Given this list of marker genes Upf1, Cnot6, Hnrnpab, Upf2, Igf2bp1, Ctif, Ssb, Smg7, Parn, Tut1, Tob1, Mtpap, Ptbp1, Pabpn1l, Gtpbp2, Xrn1, Samd4, Pan3, Eif3e, Pym1, Cnot8, Patl2, Zc3h12a (NCBI Gene Id 230738), Pde12, Dcp1b, Apobec1, Thrap3, Magoh, Rbm8a, Smg8, Smg1, Smg9, Pelo, Smg5, Cnot6l, Dhx34, Pnrc1, Edc3, Atm, A1cf, Tut4, Samd4b, Smg6, Cnot3 (CCR4-NOT transcription complex, subunit 3), Eif4a3, Rc3h1, Ddx5, Secisbp2, Exosc5 (exosome component 5), Paip1, Exosc9, Patl1, Syncrip, Polr2g, Lsm1, Hnrnpd, Dxo, Tent4b, Exosc2, Ago2, Etf1, Gspt1, Dcps, Rc3h2 (NCBI Gene Id 77277), Lsm4, Lsm7, Tnrc6c, Eif4enif1, Casc3, Caprin1, Upf3b, Cnot7, Dis3l2, Ncbp2, Eri1, Skic2, Noct, Dcp1a, Hnrnpu (NCBI Gene Id 98724), Tut7, Zfp36l2, Eif4a3l1, Cpeb3, Exosc6, Dhx36, Upf3a, Zfp36l3, Gspt2, Tnrc6b, Tesk1, Ybx1 (Y box protein 1), Exosc3, Tnrc6a, Btg2, Cnot2, Zfp36, Dis3, Cnot1, Rbm8a2, Pnldc1, Exosc7, Hbs1l, Xrn2, Tent2, Exosc8, Zfp36l1, Pabpc1, Skic3, Exosc10, Skic8, Mlh1, Tent4a, Dcp2, Ncbp1, Ago1, Eif4a3l2, Nbas, Exosc4, Csde1 (cold shock domain containing E1, RNA binding), Rnps1, Nbdy, Pnrc2, Magohb, Mrto4, Edc4, Zcchc7 (zinc finger, CCHC domain containing 7), Dhx9, Pan2, here is a description of the gene set: Mouse Gene Set: GOBP_NUCLEAR_TRANSCRIBED_MRNA_CATABOLIC_PROCESS species: Mus musculus The chemical reactions and pathways resulting in the breakdown of nuclear-transcribed mRNAs in eukaryotic cells.